Given this list of marker genes Zranb3, Smarca1, Trp53, Rad54l, Smarcal1, here is a description of the gene set: An ATP-dependent activity that facilitates the formation of a complementary double-stranded DNA molecule. Mouse Gene Set: GOMF_ATP_DEPENDENT_DNA_DNA_ANNEALING_ACTIVITY studied in species Mus musculus